Given this list of marker genes PTPN23, IL4, MIR379, MARVELD3, ADIPOR1, MCC, DAB2IP, MIR130A, MACIR (macrophage immunometabolism regulator), DUSP10, CD63, TACSTD2, EVL, PTPRR, PTPRG, CORO1C, PTEN, EPPK1, PFN2, here is a description of the gene set: Human Gene Set: GOBP_NEGATIVE_REGULATION_OF_EPITHELIAL_CELL_MIGRATION studied in species Homo sapiens Any process that stops, prevents, or reduces the frequency, rate or extent of epithelial cell migration.